Given this list of marker genes Map3k5, Adamts1, Frs2, Mdm2, Nr4a3, Ddr2, Mmp9 (NCBI Gene Id 99431), Htr1b, Dnmt1, Src, Igf1, Mmp2, Bmpr1a, Nox1, Fgfr2, Jak2, Gja1, Gnai2, Tert, Ldlrap1, Foxj2, Tnf, Ddx39b, Nf1 (NCBI Gene Id 320618), Calcrl, Ppargc1a, P2ry6 (pyrimidinergic receptor P2Y, G-protein coupled, 6), Map3k7, Camk2d, Agtr1a, Mef2d, Agt, Fgf2, Ern1 (endoplasmic reticulum to nucleus signalling 1), Jun, Grk2, Fgf9, Pdgfb, Hpgd, Pak1, Xbp1, Nqo2, Edn1, Gnai3, Igfbp5, Mfn2, here is a description of the gene set: Any process that activates or increases the frequency, rate or extent of vascular smooth muscle cell proliferation. species: Mus musculus Mouse Gene Set: GOBP_POSITIVE_REGULATION_OF_VASCULAR_ASSOCIATED_SMOOTH_MUSCLE_CELL_PROLIFERATION